The following is a description of a gene set: studied in species Homo sapiens This COVID-19 pathway has been created by a combination of computational inference from SARS-CoV-1 data (https://reactome.org/documentation/inferred-events) and manual curation, as described in the summation for the overall SARS-CoV-2 infection pathway. Steps of SARS-CoV-2 genome replication that have been studied directly include binding of the replication transcription complex (RTC) to the RNA template and the polymerase activity of nsp12, helicase activity of nsp13, capping activity of nsp16, and polyadenylation of SARS-CoV-2 genomic RNA. Replication is localized in double-membrane vesicles (DMVs) that are created by distortion of ER membranes. One host factor needed for formation of these replication organelles is phosphatidic acid. Other steps have been inferred from previous studies in SARS-CoV-1 and related coronaviruses.<br><br>The plus strand RNA genome of the human SARS coronavirus 1 (SARS-CoV-1) is replicated by the viral replication-transcription complex (RTC) composed of nonstructural proteins nsp3-nsp16, encoded by open reading frames ORF1a and ORF1b. Two RTC proteins, nsp8 and nsp12, possess 5'-3' RNA-dependent RNA polymerase activity. nsp12 is the main RNA polymerase, while nsp8 is thought to act as an RNA primase. nsp14 acts as a 3'-5' exonuclease, increasing the fidelity of the RTC. nsp14 also has the RNA capping activity and, in concert with nsp16, it caps viral plus strand and minus strand genomic and subgenomic RNAs, which confers stability to viral RNAs by enabling them to escape interferon-mediated innate immune responses of the host. nsp13 is an RNA helicase which is thought to melt secondary structures in the genomic RNA during replication and transcription. The plus strand genomic RNA is first used to synthesize the minus strand genomic RNA complement, which is subsequently used as a template for synthesis of plus strand viral RNA genomes that are packaged into mature virions. For review, please refer to Yang and Leibowitz 2015, Snijder et al. 2016, Fung and Liu 2019. Reactome Pathway: Replication of the SARS-CoV-2 genome part of: SARS-CoV-2 Genome Replication and Transcription, and this is the list of marker genes: DDX5, RB1, VHL, rep, SARS coronavirus, complete genome, ZCRB1, pp1a